Given this list of marker genes AKR1E2, HLA-DOB, SEMA5A (semaphorin 5A), MAPK13, PCDHB14, BMP15, GLIPR2, NCAM1, ALG2, NGFR, ZPBP, RNF17, FUT1, DPPA2, GPX6, AMOT, SLFN12, TLR4, RWDD3, CIT, MITF, CCKBR, RHOH, BUD31, SOWAHA, PKIB, ITSN1, PAX9, MAGEA4, AQR, OPRD1, TTI2, SRSF2, HHIP, SMARCAD1, CELA3B, HAND1, CCDC43, CHN1, CTC1, FBXO33, CD8A, CKLF, KLK1, SPZ1, SORCS2 (sortilin related VPS10 domain containing receptor 2), FZD3, IP6K1, CTSL, CASTOR2, PAPPA, STK26, JAG1, IGBP1, FJX1, ELAVL4, KCNJ4, LCE1B, IGLV7-43, NAA11, SMC1B, CLGN, MLPH, CCR10, LAMC2, CRYGS (NCBI Gene Id 1427), KCNK4, DTD2, CHST6, KCND3, SYNCRIP, DSC1, CABP1, NRK, ADAM3A, OTUD7A, MARK4, ZNF474, IL7, TCF3, NEIL3, ELOVL4, EPYC, LRP2, ORC2, UBE2E3, IGF1R, MIGA2, TNFRSF13C, SPOCK3, TAF7L, RAB3IL1, APC2, MYH7, LDHC, PI15, ZBTB21, MCUB, SLAMF1, LDLRAD4, POLH, ZBTB45, AIPL1, CD40 (NCBI Gene Id 958), TBX2 (T-box transcription factor 2), IAPP, FGD4, SP4, CEACAM4, SLC1A3, RUNX1, here is a description of the gene set: species: Mus musculus Human Gene Set: SHETH_LIVER_CANCER_VS_TXNIP_LOSS_PAM5 from publication Sheth SS, Bodnar JS, Ghazalpour A, Thipphavong CK, Tsutsumi S, Tward AD, Demant P, Kodama T, Aburatani H, Lusis AJ (PMID 16607285) The molecular pathogenesis and the genetic aberrations that lead to the progression of hepatocellular carcinoma (HCC) are largely unknown. Here, we demonstrate that the thioredoxin interacting protein (Txnip) gene is a candidate tumor suppressor gene in vivo. We previously showed that the recombinant inbred congenic strain HcB-19 has a spontaneous mutation of the Txnip gene, and we now show that the strain has dramatically increased incidence of HCC, and that the HCC cosegregates with the Txnip mutation. Approximately 40% of the Txnip-deficient mice developed hepatic tumors with an increased prevalence in male mice. Visible tumors develop as early as 8 months of age. Histological analysis confirmed the morphology of HCC in the Txnip-deficient mice. Molecular markers of HCC, alpha-fetoprotein and p53, were increased in tumors of Txnip-deficient mice. The upregulation of p53 preceded tumor development; however, bromodeoxyuridine (BrdU) labeling of normal hepatic tissue of Txnip-deficient mice did not reveal increased cell proliferation. Finally, microarray analyses of tumor, non-tumor adjacent, and normal tissue of Txnip-deficient mice highlighted the genetic differences leading to the predisposition and onset of HCC. Our findings suggest that Txnip deficiency is sufficient to initiate HCC and suggest novel mechanisms in hepatocarcinogenesis. Cluster PAM5: genes changed exclusively in hepatocellular carcinoma (HCC) samples from 27 month old mice deficient for TXNIP.